The following is a description of a gene set: from publication Jiang CH, Tsien JZ, Schultz PG, Hu Y (PMID 11172053) A better understanding of the molecular effects of aging in the brain may help to reveal important aspects of organismal aging, as well as processes that lead to age-related brain dysfunction. In this study, we have examined differences in gene expression in the hypothalamus and cortex of young and aged mice by using high-density oligonucleotide arrays. A number of key genes involved in neuronal structure and signaling are differentially expressed in both the aged hypothalamus and cortex, including synaptotagmin I, cAMP-dependent protein kinase C beta, apolipoprotein E, protein phosphatase 2A, and prostaglandin D. Misregulation of these proteins may contribute to age-related memory deficits and neurodegenerative diseases. In addition, many proteases that play essential roles in regulating neuropeptide metabolism, amyloid precursor protein processing, and neuronal apoptosis are up-regulated in the aged brain and likely contribute significantly to brain aging. Finally, a subset of these genes whose expression is affected by aging are oppositely affected by exposure of mice to an enriched environment, suggesting that these genes may play important roles in learning and memory. Human Gene Set: JIANG_AGING_HYPOTHALAMUS_DN Down-regulated in the hypothalamus of aged (22 months) BALB/c mice, compared to young (2 months) controls studied in species Mus musculus, and this is the list of marker genes: VSNL1, ATP9A (NCBI Gene Id 654090), DNAJA2, EPRS1, GRIA1, CPE, ATP1B2, ACHE, ATP6AP1, AP2M1, CANX, ACO2, PRKACB, FSTL1, KIF5B, STIP1, SARS1, SYT1, DDB1, RAB18, PLD3, ATP6V1E1, CS, CAMK2G, GDI1 (NCBI Gene Id 2664), PTGDS, GPX4, EPAS1, MGAT2, DLG4, APOE, VTI1B, UBC, DHX30, DNM1